The following is a description of a gene set: species: Homo sapiens Reactome Pathway: Severe congenital neutropenia type 4 (G6PC3) Glucose-6-phosphatase 3 (G6PC3) associated with the endoplasmic reticulum membrane normally catalyzes the hydrolysis of glucose-6-phosphate to glucose and orthophosphate. In the body, this enzyme is ubiquitously expressed; mutations that inactivate it are associated with severe congenital neutropenia (but not with fasting hypoglycemia or lactic acidemia). part of: Glycogen storage diseases, and this is the list of marker genes: G6PC3